The following is a description of a gene set: studied in species Homo sapiens Genes in the cancer module 286 Human Gene Set: MODULE_286, and this is the list of marker genes: HADHB, CRYZL1, ADH4, HPGD, LDHC, NSDHL, HSD17B2, ME1, GPD1, HMGCR, ADH1A, XDH, HADHA, HSD17B7, HSD17B4, FASN (NCBI Gene Id 2194), HSD17B3, HSD11B1, ADH1C, IMPDH2, MDH1, LDHA (NCBI Gene Id 3939), IDH2, IDH1, TP53I3, EHHADH, CBR3, AKR7A2, CRYZ, MDH2, AKR1B1, UGDH, CBR1, IDH3A, HSD17B10, SORD, SPR